Given this list of marker genes TUBB6, HBG1, IFNA2, DOCK1, GATA4, CAPZA2, ZFPM1, HBD, KIF20B, KIF15, VPS45, KIF21A, KIF6, EHD1, CDC42, IFNA10, KIF3A, KIF9, MAFK, KIF18A, RAC1, NFE2, KIF21B, KIF4A, TUBAL3 (NCBI Gene Id 79861), TUBB4B, DOCK8, AKAP1, HBB, H3C15, CDK2, TUBB2A, PRKAR2A (NCBI Gene Id 5576), TUBA3C, DOCK10, AKAP10, CAPZB, KIF1B, HDAC1, KLC3 (NCBI Gene Id 8185), KIF22, AK3, CABLES1, KIF1C, TUBA1C, ABL1, IFNA14, EHD2, DOCK5 (NCBI Gene Id 80005), CAPZA1, TUBB4A, MAFG, GATA5, RBSN (rabenosyn, RAB effector), GATA1, KIF4B, MYB, DOCK2, KLC2, ACTB, RAD51C, KIFC1, HMG20B, MICAL1, CARMIL1, KIF25, GATA6, HBE1, KIF12, TP53, TUBB2B (tubulin beta 2B class IIb, NCBI Gene Id 347733), CENPE, TUBB3, PRKAR1A, ZFPM2, DOCK4, IRF2, TUBA8, KIF5C, TUBA3E, TUBA1B, KIFC2, DOCK11, IFNA16, RAB5A, TUBA3D, H3-3A, KIF11, PRKAR1B (NCBI Gene Id 645590), KIF20A (NCBI Gene Id 94421), DOCK3, KIF28P, KIFAP3, H3C1, PHF21A, KIF2A, IFNA8, DOCK7, IFNA17, KIF19, MAFF, TUBB1 (NCBI Gene Id 81027), IFNA21, ITPK1, DOCK6, MFN2, SIN3A, KIF3C, TUBB8, KIF16B, PRKACG, KIF18B, TUBB8B, KIF5A, MFN1, KIF23, SH2B3, IFNA6, SH2B2, KIF3B, SH2B1, JAK2, KIF2C, KIF26B (NCBI Gene Id 55083), GATA3, CABLES2, KDM1A, KLC4, TUBA4A, PRKACA, CDK5, RACGAP1, GATA2, DOCK9, IRF1, IFNA5, KIF13B, JMJD1C, IFNA7, PRKAR2B, RCOR1, KIF26A, CBX5, RAD51B, IFNA1, HDAC2, IFNA4, KIF1A, PRKACB, EHD3, TUBA1A, TUBA4B, HBG2, IFNA13, IFNB1, KIF27, KLC1, WEE1, KIF5B, KIF2B, here is a description of the gene set: part of: Hemostasis Reactome Pathway: Factors involved in megakaryocyte development and platelet production Megakaryocytes (MKs) give rise to circulating platelets (thrombocytes) through terminal differentiation of MKs which release cytoplasmic fragments as circulating platelets. As MKs mature they undergo endoreduplication (polyploidisation) and expansion of cytoplasmic mass to cell sizes larger than 50-100 microns, and ploidy ranges up to 128 N. As MKs mature, the polyploid nucleus becomes horseshoe-shaped, the cytoplasm expands, and platelet organelles and the demarcation membrane system are amplified. Proplatelet projections form which give rise to de novo circulating platelets (Deutsch & Tomer 2006). <br>The processes of megakaryocytopoiesis and platelet production occur within a complex microenvironment where chemokines, cytokines and adhesive interactions play major roles. Megakaryocytopoiesis is regulated at several levels including proliferation, differentiation and platelet release. Thrombopoietin (TPO/c-Mpl ligand) is the most potent cytokine stimulating proliferation and maturation of MK progenitors but many other growth factors are involved. MK development is controlled by the action of multiple transcription factors. Many MK-specific genes are co-regulated by GATA and friend of GATA (FOG), RUNX1 and ETS proteins. Nuclear factor erythroid 2 (NF-E2), which has an MK-erythroid specific 45-kDa subunit, controls terminal MK maturation, proplatelet formation and platelet release (Schulze & Shivdasani 2004). NF-E2 deficient mice have profound thrombocytopenia. MYB (c-myb) functions with EP300 (p300) as a negative regulator of thrombopoiesis. During MK maturation, internal membrane systems, granules and organelles are assembled. Cytoplasmic fragmentation requires changes in the MK cytoskeleton and formation of organelles and channels. Individual organelles migrate from the cell body to the proplatelet ends, with approximately 30 percent of organelles/granules in motion at any given time. studied in species Homo sapiens